Given this list of marker genes COL1A1, VWF, COL1A2, here is a description of the gene set: Reactome Pathway: Defective VWF binding to collagen type I studied in species Homo sapiens part of: Defects of platelet adhesion to exposed collagen Upon vascular injury, circulating von Willebrand factor (VWF) binds to exposed vascular collagen.